Given this list of marker genes PAFAH1B1, GLI3, SOCS7, ADGRG1, SUN2, NDEL1, COL3A1, LHX6, CDK5R2, MDGA1, CCDC141, P2RY12, CDK5R1, DISC1, BMERB1, LAMB1, MBOAT7, POU3F3, DAB2IP, FUT10 (fucosyltransferase 10), SUN1 (Sad1 and UNC84 domain containing 1), SRGAP2, CDK5, FBXO45, FOXG1, SYNE2, LRP8, RAC1, CTNNB1, POU3F2, DAB1, DIXDC1, NR2E1, SRGAP2C, RELN, ZMIZ1, RTN4, WDR47, here is a description of the gene set: Human Gene Set: GOBP_CEREBRAL_CORTEX_RADIALLY_ORIENTED_CELL_MIGRATION The migration of cells in the developing cerebral cortex in which cells move from the ventricular and/or subventricular zone toward the surface of the brain. species: Homo sapiens